Given this list of marker genes Fth1, Tmem234, H2-Aa, Slc6a6, Cd74, Insr, Npnt, Ripply3, Apoe, Sod1, Kap, Epas1, Syne1, H2-K1, Herc1, Rps10, H2-Ab1, Mcam, Mxra7 (NCBI Gene Id 78554), Ctla2a, H2-Eb1, Ybx1, Plac9, Pcolce2, Timp3, B2m, Napsa (NCBI Gene Id 16541), Ifi27l2a, Plac8, Eng, Gnai2, Gpx3, here is a description of the gene set: Mouse Gene Set: TABULA_MURIS_SENIS_KIDNEY_KIDNEY_CORTEX_ARTERY_CELL_AGEING studied in species Mus musculus from publication Tabula Muris Consortium (PMID 32669714)